The following is a description of a gene set: Mouse Gene Set: GOBP_MEGAKARYOCYTE_DEVELOPMENT studied in species Mus musculus The process whose specific outcome is the progression of a megakaryocyte cell over time, from its formation to the mature structure. Megakaryocyte development does not include the steps involved in committing a cell to a megakaryocyte fate. A megakaryocyte is a giant cell 50 to 100 micron in diameter, with a greatly lobulated nucleus, found in the bone marrow., and this is the list of marker genes: Tesc, Gp9, Gp1bb, Srf, Meis1 (NCBI Gene Id 353058), Abi1, Ep300, Mpig6b, Fli1, Gp1ba, Wasf2, Vps33b, Tal1, Zfp385a, Nbeal2, Rabgap1l, Sh2b3, Ptpn6, Ptpn11, Kit, Gp5, Thpo, Zfpm1, Med1, Pip4k2a, Flna